The following is a description of a gene set: from publication Martoriati A, Doumont G, Alcalay M, Bellefroid E, Pelicci PG, Marine JC (PMID 15608685) species: Mus musculus Genes up-regulated in apoptotic tissues (neuroepithelium) after MDM4 knockout. The p53 tumour suppressor functions as a transcriptional activator, and several p53-inducible genes that play a critical proapoptotic role have been described. Moreover, p53 regulates the expression of various proteins participating in autoregulatory feedback loops, including proteins that negatively control p53 stability (Mdm2 and Pirh2) or modulate stress-induced phosphorylation of p53 on Ser-46 (p53DINP1 or Wip1), a key event for p53-induced apoptosis. Here, we describe a new systematic analysis of p53 targets using oligonucleotide chips, and report the identification of dapk1 as a novel p53 target. We demonstrate that dapk1 mRNA levels increase in a p53-dependent manner in various cellular settings. Both human and mouse dapk1 genomic loci contain DNA sequences that bind p53 in vitro and in vivo. Since dapk1 encodes a serine/threonine kinase previously shown to suppress oncogene-induced transformation by activating a p19ARF/p53-dependent apoptotic checkpoint, our results suggest that Dapk1 participates in a new positive feedback loop controlling p53 activation and apoptosis. Human Gene Set: MARTORIATI_MDM4_TARGETS_NEUROEPITHELIUM_UP, and this is the list of marker genes: SERPINE2, MARCHF5, RNF126, CCND1, PHLDA3, AK4, LDHA, PGK1, BLOC1S2, SNORA74A, WNT3A, P4HA1, TPI1, TBX3, HSPA1B, AEN, GALK1, EI24, TAP1, SLC16A3, PROS1, SNORD49A, ANKRD37, CPNE2, MT1X (NCBI Gene Id 82523), ADM, SALL4, FOXB1, PIEZO1, NME4, ZNF365, CTHRC1, SNAI1, PTK7, VCAN, CTSE, PMAIP1, PLA2G12A, TRIM71, MAPKAPK3, FBN2, KIFC1, ZNF688, PFDN2, DEF6, IGF2R, TPD52L1, SLC66A3, SYNM, S100A10, CCNG1, P3H2, GAS5, CD81, EIF4EBP1, LNPEP, SLC39A7, BHLHE40, ID1, EDA2R, BNIP3, RPL36, SLC19A2, GPI, PIERCE1, SRRM2, EXOC4, PFKP, CDC34, GGCT, PLK2, PSRC1, TRIM6, DDX3Y, PFKL, ERO1A, LRRFIP1, ENO1, DNAI1, PTPN14, ERCC5, POLR2K, ACTN1, AK1, DAPK1, PIDD1, PEG3, DUSP5, EIF2S3, CCND2, MEG3, HK2, FGF19 (fibroblast growth factor 19), AGPAT5, GRIA3, SESN2, HIGD1A, PTPRVP, PERP, NR6A1, KRT19, GTSE1, BHLHE41, SLC2A1, MAP3K20, RPS19, CPT1C, CKAP2, TIMM17A, C12orf75, PRELID2, ARRDC3, FAM162A, FST, TP53INP1, FBXW9, FOXO3, CEP170B, NOMO1, TMEM255A, IFT20, RPGRIP1, SOAT1, COX6B2, LIN28A, NDUFB6, EGLN3, ITGA8, EGLN1, SLC2A3, LPP, PLXDC2, EPHX2, LYPD1, NKX6-2, RPL27A, PGM1, RBM38, CDK6, PRTG, GRHPR, GGTA1, DDIAS, FOXL2, ARAP2, CAD, FAM181B, DDIT4L, MYC, RNF169, CALD1, FAT1, MAB21L3, BEX1, ALDOA, DDIT4, CEP15, DCXR, ANO3, SF3B5, PALM2AKAP2, VEGFA, NAV1, BAX, ITGA9, SEM1 (SEM1 26S proteasome subunit), PTP4A3, SNRPF, IGDCC4, ENG, GPC3, MT1F, CDKN1A, KLHL26, CPPED1, DYNLT2, ZMAT3, MIX23 (mitochondrial matrix import factor 23)